The following is a description of a gene set: Genes containing one or more binding sites for (FOXF1) in their promoter regions (TSS -1000,+100 bp) as identified by GTRD version 20.06 ChIP-seq harmonization. from publication Yevshin I, Sharipov R, Kolmykov S, Kondrakhin Y, Kolpakov F (PMID 30445619) studied in species Homo sapiens Human Gene Set: FOXF1_TARGET_GENES, and this is the list of marker genes: GNAS, PDE8A, RPL4, MSL3P2 (MSL3 pseudogene 2), ASB7, MIR3914-2, RNA5SP400, KIF6, PRR13P2